Given this list of marker genes Clu (clusterin), Insm1, Mir375, Zfp800, Mir541, Nkx6-1, Hes1, Pax4, Mir7-1, Vhl, Pde3b, Neurod1, Onecut1, Wnt5a, Reg1, Men1, Nkx6-2, Bmal1, Il6, Clock, Eif2ak3, Sidt2 (SID1 transmembrane family, member 2), Bak1, Dll1, Bmp5, Cdk6, Mnx1, Sox9, Gip, Gata6, Gipr, Bad, Smo, Ier3ip1, Rfx6, Il6ra, Pax6, Rheb, Pdpk1, Cftr, Sox4, Pdx1 (pancreatic and duodenal homeobox 1), Gdf11, Myt1, Rfx3, Nkx2-2, Bhlha15, Foxa2, Mir214, Bmp6, Bmp4, Cdh2, Hnf1b, Onecut2, Mir503, here is a description of the gene set: The process whose specific outcome is the progression of the endocrine pancreas over time, from its formation to the mature structure. The endocrine pancreas is made up of islet cells that produce insulin, glucagon and somatostatin. species: Mus musculus Mouse Gene Set: GOBP_ENDOCRINE_PANCREAS_DEVELOPMENT